The following is a description of a gene set: species: Mus musculus Genes predicted to be targets of miRBase v22 microRNA mmu_miR_743a_5p, mmu_miR_871_5p in miRDB v6.0 with MirTarget v4 prediction scores > 80 (high confidence targets). from publication Chen Y, Wang X (PMID 31504780) Mouse Gene Set: MIR_743A_5P_MIR_871_5P, and this is the list of marker genes: Copb1, Lyset, Armcx2, Eif4b, Grk4, Ccnc, Cdk19, Dhx32, Eogt, Cbfb, Eif4a1, Mfsd4b5, Cacna1e, Fbxo33, Lclat1, Sorcs1, Smim17, Sprr2e, Ogfr, Rock2, Pclaf, Kdm7a, Rbm27, Cd53, Mfsd6, Pdia4, Myt1l, Cnot6, Hnrnph3, Nufip2, Pcdhb11, Bche, Ogt, Egfl6, Serpina3c, Magi1, Ankrd28, Cdk8, Trub1, Tmbim1, Sox6, Trio, Adnp, Zdhhc21, Yipf4, Spag9, Spry1, Enc1, Rgs20, Macc1, Tex16, Kansl1, Cpne4, Pfn1, Prdm14, Dach2, Plek, Rrp8 (ribosomal RNA processing 8), Msl2, Atp6v0a2, Dkk1, Ostm1, Tnfrsf13c, Gimap9, Cd34, Mfhas1, Homer1, Il22ra2, Pla2g2e, Manea, Lpp, Phlda1, Atp5mg, Rpa3, Atg4a, Rfx7, Kpnb1, Dync1i2, Synpr, Fancm, Cep192 (centrosomal protein 192), Ptprn2, Cyria, Foxn3, Spsb4, H2bc6, Zfp459, Igsf1, Tslp, Mtss1, Plpp6, Tnfrsf11b, Qki, Dcaf8l, Txndc16, Hcn1, Cds1, Tmem106b, Fam110d, Casp7, Gucy1a2, Dock3 (NCBI Gene Id 638531), B4galt1, H6pd, Grik2, Thsd7b, Slc7a6, Bcor, Uqcc5, Adam12, Pdia5, Pus3 (pseudouridine synthase 3), Mapk14, Sprr2k, Tmco1, Grik4, Zfp780b, Sprr2h, Slitrk5, Zfp423, Zbtb33, Lamc1, Clec3a, Man1a2, Cpsf6, Irs4, Trim30a, Zfp280d (NCBI Gene Id 260391), Pgap1, Smarcad1, Minar1, Pcmtd1, Kcnc2, Abca5, Tmem109, Impdh1, Slc7a1, Rp2, Maff, Hnf4g, Fam168b, Mcc (mutated in colorectal cancers), Pank3, Akr7a5, Zbtb41, Zfp971, Dock4 (dedicator of cytokinesis 4), Tacr3 (tachykinin receptor 3), Slmap, Trim21, Yme1l1, Mob1b, Lamtor2, Wfdc12, Erich4, Rac2, Hspa4, Slc18a2, Mettl6 (NCBI Gene Id 67011), B3galt2 (UDP-Gal:betaGlcNAc beta 1,3-galactosyltransferase, polypeptide 2), Arpp19, Zcchc3, Fancc, Dkk2, Katna1, Nfat5, Ppp1r1c, Cd93, Ttc32, Il20ra, Lrrc28, Nxpe5 (neurexophilin and PC-esterase domain family, member 5), Rfx3, Edn1, Esp18, Thsd7a, Zfr